Given this list of marker genes MARCHF6, GNA13, ZRANB3, JUNB, PPP2R5C, CD70, AIP, MICU1, CALML4, HMGCS1, GNS, SLC2A3, SPOP, MAP2K2, LRIG2, POU2F2, SF3A2, FNIP1 (folliculin interacting protein 1), TIFA, WAC, IL21R, PNKP, OIP5-AS1, FAM162A, MYADM, SRRT, MAPRE2, TUBE1, NUCB2, WDFY1, ALDH16A1, CMTM8, MID1IP1, GABARAP, PPP1R18, GBE1, BTG2, FAHD2A, TGFB1, METRNL, GNB2, CREBRF (NCBI Gene Id 153222), SESTD1, BCL2L11, TPP1, TMEM120A, CD55 (CD55 molecule (Cromer blood group)), SIPA1, KDELR1, PPP1R9B, KAT8, TM2D1, PACS1, MEF2A, INHBE, METTL9, SAMD1, PHGDH, CDK10, TMED4, GNG7, CCNB1IP1, TRIO, SUCLG2, CTBS, SPARCL1, INTS6, FDFT1 (farnesyl-diphosphate farnesyltransferase 1), CPNE1, MSMO1, DUSP5, RALA, RAB39B, RSRC1, MAP4K1, IFRD1, SGPP1, PBXIP1, CHI3L2, CSNK1E, CTNNA1, ICAM1, CD37, TTC3, ZMYM2, TPRA1, BRAF, MPST, PCGF5, TAFAZZIN, ATXN2L, DDIT4, P4HA1, FXYD5, HNRNPUL1, CD99L2 (NCBI Gene Id 83692), CALR (calreticulin), PIM2, ZNF318, WNT10A, KPNA1, LSS, RPL31, SESN2, NADK, AKAP13, WWOX, KIAA0319L, ACTMAP (NCBI Gene Id 284325, actin maturation protease), USP47, ZFP36L1, PIGO, MTA1, SCD, AHCYL1, CNOT6L, ASMTL, PARVB, AGPAT1, VEGFA, STX16, TSPO, HIBADH, ZNF627, PCK2, NFE2L1, LRRC28, TKFC, KIF3A, SOX5, LHFPL6, LDLR, PKP2, RAB11B, MAST2, CARS1, DOK3, CDT1, NPIPB3, NFAT5 (nuclear factor of activated T cells 5), AURKB, IL10RB, PMAIP1 (NCBI Gene Id 9305), HERC3, RPL13A, GAA, ABHD6, IL2RG, CLEC2B, POLDIP3, STAT5B, PLEK, ATF4, CARMIL2, RELB, STS, SAT1, ALKBH7, GKAP1, PIK3IP1 (phosphoinositide-3-kinase interacting protein 1), LETMD1, VLDLR, YWHAE, PJA2 (NCBI Gene Id 9867), WDR33, CD69, MARCHF9, MKRN1, HCFC1R1, TOR3A, NAT14, SCARB1, ERLIN2, PKN2, CBS, ZDHHC5, NLRP11, MARCHF1, DHCR7, ASAP1, AAAS, PPARA (peroxisome proliferator activated receptor alpha), ARID1A, UACA, GPI, KYAT3, WARS1, REXO5, MKNK2, RUNX3, PDCD4, MEGF9, LEPR, SHKBP1, UBXN7, ALOX5, RBM39, NR1H2, UHMK1, NCOA3, GM2A, SMIM27, LPIN1, CD52, RIMS3, LSP1, TP53, NUP210, AMFR, UCP2, SEPTIN6, PKN1, BAP1, ARHGDIA (Rho GDP dissociation inhibitor alpha), WIPF1, MIF4GD (NCBI Gene Id 57409), PTOV1, CCL3, NPC2, CCL4, SPIC, GRINA, NEAT1, STRN4, KDM4B, STK4, CYP51A1, POLD4, APEH, SLC25A1, RGS1, KLHDC2, MBP, IFT80, GARS1, HSF1, CADPS, ZNF581, TPM4, THAP4, PI4KB, SC5D, NFKBIA, CDK16, CCNG1, NAXE, CD48, GCHFR, TRIM69, LENG8, GATAD1, ZFAND3, AARS1, PRKCSH, SHMT2, CAMLG, BTBD7, CDKN1A, MND1, LRRC41 (leucine rich repeat containing 41), CEBPB, TRAK1, NOS3, BCL2A1, EEIG1, UST, NME4, SQSTM1, MARK4, GRAMD1A, VAMP2, KLHL24, FYN, NAGLU, LRSAM1, IL10, BORCS8-MEF2B, TSTD1, ZC3H11A, EVI2A, ACKR3, UQCRC1, NLK, DHTKD1, SDCBP, TARS1 (threonyl-tRNA synthetase 1), HPCAL1, UBE2R2, DHRS7 (NCBI Gene Id 51635), LTN1, STX17, SUSD3, GFI1B, ACLY, TMC8, NFKB2, SH3GLB2, DMPK, AP2A1, HMG20B, LCK (NCBI Gene Id 95387), PDK1, CD22, MAP1LC3B, KDM6B, MYLIP, INSIG1, MACROD1, GRK2, SPI1, ESD, ARL2, HMGCR, STAT1, FOXN3 (NCBI Gene Id 654111), ANKRD11, AUH, IRF9, GRK3, TLN1, MRPL2, PPP1R10, FGR, DARS1, ZNF207, HMGA1, MAP1S, BCL3, ENO2, TAF15, SET, SLC38A2, LAMA3, SLC1A4, PILRB, SLC35A3, RNU6-1016P, CAMK2D, SLC7A1, SECISBP2L, BNIP3L, SLC3A2, SLC1A5, FOXK2, CAB39, STYXL1, TNIP2, SERINC3, CALM3, TLR9, PSAT1, CD72, WASF2, PRRC2A, CD74, BCL2 (BCL2 apoptosis regulator), SORL1, MARS1, TKT, DAPK3, SQLE, SULT1A1, ACY1, DENND11, SELENOO, WSB1, DCAF7, KCNN3, SLC43A1, R3HDM2, CEBPG, PTPN6, DESI2, TIPRL, IGHM, PHF13, PPP1R14B, UVSSA, TYSND1, ZFP36L2, DPP7, MINK1, CTH, SREBF2, NF1, PHF14, ZNF277, MALAT1, UBXN6, ATP5F1D, CYSTM1 (cysteine rich transmembrane module containing 1), ALDOC, CNOT3, NBEAL2, TRIM4, TMPRSS15, WAS, FASN, WNK1, GNAI2 (G protein subunit alpha i2), VMP1, STN1, ASL, PGK1, PIGP, FLOT1, SLC25A37, ASNS, IRF2BP2, BCKDK, TMC6, CAPNS1, JUND, HLA-E, HSD17B8, DYNC2I2, OGFR, RBFOX2, TNFSF9, MGAT4B, CCR7, GSK3B, SLC44A2, SOCS7, ETHE1, PAN2, CDC42, TBL1X, TAGAP, ALDH6A1, PFKL, TNFAIP3, WBP2, GNB1, P2RX5, MAPK9, LRBA, SYNGR3, GART, DDX17, ASCC1, MIDN, TAF1, MAP2K3, LILRB4, SPIB, CD83, MFHAS1, APBB2, GPR160, RGS16, DHPS, LPCAT4, HELLS, TBC1D1, IDH2, SLC7A11, TUBGCP3, GLCCI1, LDAF1, DYNC2LI1, TCF4 (NCBI Gene Id 6925), IRF1, SLC39A9, DBP, KIF21B, GTPBP1 (NCBI Gene Id 9567), AGRN, TAOK1, MAZ, ST6GALNAC4, here is a description of the gene set: Chronic lymphocytic leukemia (CLL) results in the accumulation of B cells, presumably reflecting the selection of malignant cell precursors with Ag combined with complex alterations in protein activity. Repeated BCR stimulation of normal B cells leads to anergy and CD5 expression, both of which are features of CLL. Because CD5 is phosphorylated on tyrosine following BCR engagement and negatively regulates BCR signaling in normal B cells, we investigated its phosphorylation status and found it to be naturally phosphorylated on tyrosine but not on serine residues in CLL samples. To analyze the role of CD5, we established a B cell line in which CD5 is phosphorylated. Gene profiling of vector vs CD5-transfected B cells pointed out gene groups whose expression was enhanced: Apoptosis inhibitors (BCL2), NF-kappaB (RELB, BCL3), Wnt, TGFbeta, VEGF, MAPKs, Stats, cytokines, chemokines (IL-10, IL-10R, IL-2R, CCL-3, CCL-4, and CCR7), TLR-9, and the surface Ags CD52, CD54, CD70, and CD72. Most of these gene groups are strongly expressed in CLL B cells as compared with normal B cells. Unexpectedly, metabolic pathways, namely cholesterol synthesis and adipogenesis, are also enhanced by CD5. Conversely, CD5 inhibited genes involved in RNA splicing and processing, ribosome biogenesis, proteasome, and CD80 and CD86 Ags, whose expression is low in CLL. Comparison of CD5- vs tailless CD5-transfected cells further demonstrated the role of CD5 phosphorylation in the regulation of selected genes. These results support a model where CLL cells are chronically stimulated, leading to CD5 activation and cell survival. In addition to CD5 itself, we point to several CD5-induced genes as potential therapeutic targets. Genes up-regulated in Daudi cells (B lymphocytes) stably expressing CD5 off a plasmid vector. from publication Gary-Gouy H, Sainz-Perez A, Marteau JB, Marfaing-Koka A, Delic J, Merle-Beral H, Galanaud P, Dalloul A (PMID 17878328) Human Gene Set: GARY_CD5_TARGETS_UP studied in species Homo sapiens